The following is a description of a gene set: The memory process that deals with the storage, retrieval and modification of information a long time (typically weeks, months or years) after receiving that information. This type of memory is typically dependent on gene transcription regulated by second messenger activation. Mouse Gene Set: GOBP_LONG_TERM_MEMORY species: Mus musculus, and this is the list of marker genes: Ctns, Btbd9, Lrrn4, Sgk1 (serum/glucocorticoid regulated kinase 1), Shank1, Lcn2, Camk2n1, Slc2a4, Mtor, Adcy8, Ehmt2, Cpeb3, Arc, Acss2, Apoe, Ccnd2, Glud1, Npas4, Calb1, Tac1, Eif2ak4, Ntrk2, Reln, Gria1, Drd2, Ptchd1, Snap25, Adcy1, Srf, Kat2a (NCBI Gene Id 76912), Mecp2, Camk4, Chst10, Grin1, Rps6kb1, Prkcz, Ntf5, Slc17a7, Trpm4, Nfatc4, Ldlr, Tacr1, Crebbp, Pja2, Rgs14, Egr1